The following is a description of a gene set: species: Homo sapiens Any process that activates or increases the frequency or rate of heart contraction. Human Gene Set: GOBP_POSITIVE_REGULATION_OF_HEART_RATE, and this is the list of marker genes: EDN1, PTPN1, ADM, AVPR1A, EDN2, SCN3B, HEY2, EDN3, RGS4, PDE4D, NMU, GCH1, HRC, ADRB1, ATP2A2, TPM1 (tropomyosin 1), ADM2, ADA, RYR2, APLN, KCNQ1, ADM5, MIR1-1, NPPA, TRPM4, TACR3, ADRA1A, SLC1A1